The following is a description of a gene set: Mesomelia studied in species Homo sapiens Human Gene Set: HP_MESOMELIA Shortening of the middle parts of the limbs (forearm and lower leg) in relation to the upper and terminal segments., and this is the list of marker genes: LBR, EIF4A3, PRKG2, SIK3, DVL3, GDF5, RMRP, ROR2, WNT5A, TBX15, TONSL, SHOX, ACAN, CREB3L1, DVL1, NEK1, NXN, CTSK (cathepsin K), NPR2, DHCR7 (NCBI Gene Id 6589), ZSWIM6, IFT80, FGFR3, WDR35, GLI3, AFF3 (ALF transcription elongation factor 3), DONSON, TRIP11, RAC1, KIF15, ESCO2, GPC6, PTH1R, NGLY1, FLNA